The following is a description of a gene set: Catalysis of the reaction: ATP + 1D-myo-inositol hexakisphosphate = ADP + diphospho-1D-myo-inositol-pentakisphosphate. The isomeric configuration of diphospho-1D-myo-inositol-pentakisphosphate (PP-IP5) is unknown. Human Gene Set: GOMF_INOSITOL_HEXAKISPHOSPHATE_KINASE_ACTIVITY species: Homo sapiens, and this is the list of marker genes: IP6K3, PPIP5K2, PPIP5K1, IP6K2, IP6K1, ITPKB, ITPKC, ITPKA